Given this list of marker genes PYROXD1, SGCG, TNPO3, HACD1, EBF3, DNM1L, OBSL1, CHRNE, ANXA11, PAX3, GDF11, FKRP, ALG14, PTPN11, CRPPA, MYBPC1, ANO5, CHRNA1, PLIN4, FILIP1, TWNK, POLG2, MYMX, CHRNB1, DNMT3B, DYSF, SYNE1, TNNT1, SLC25A4, FRG1, CAPN3, MATR3, DPAGT1, DUX4, MYMK, KBTBD13, EYA1, BRAF, POMT2, AK9, GALC, DMD, TMEM43, MT-TE, CFL2, TRPS1, COLQ, DNA2, PNPLA2, PSAP, GNE, ACTA1, MYOT, VCP, ABHD5, SQSTM1, LRP4, SALL4, HNRNPDL, TTN, SELENON, TRIM32, GFPT1, COL13A1, GMPPB, POLG, FHL1, SYNE2, TK2, KLHL41, ATP6V0A2, ALX1, NEFL, ALX3, SGCB, MYH2, OPA1, RYR1, COL6A2, MYH7, COL6A1, PAX1, LAMB2, DNAJB6, ITGA7, SCN4A, FKTN, DUX4L1, GDAP1, LMNA, TBX3, SEPTIN9, ITPR1, SPEG, COL12A1, VWA1, MYL2, EMD (emerin), SMPX, MYPN, SMN1, RYR3, LGI4, GYG1, FLNB, PLXND1, COL6A3, SPTLC1, TRIO, TPM3, SMN2, CSGALNACT1, RAF1, FLNA, SPRED2, PRR12, PUS1, ASH1L, AGRN, REV3L, CRYAB, C19orf12, TPM2, SMCHD1, CUL7, FBN1, POGLUT1, BIN1, RBM8A, DSTYK, ALG2, MUSK, TRPV4, NEB, EMILIN1, CCDC8 (NCBI Gene Id 83987), TBX5, DOK7, BICD2, RAPSN, TGFB3, MAP3K7, SGCA, FLNC, CHRND, MAP3K20, RRM2B, KCNJ2, LRIF1, SGCD, BAG3, here is a description of the gene set: Abnormality of the shoulder girdle musculature species: Homo sapiens Human Gene Set: HP_ABNORMALITY_OF_THE_SHOULDER_GIRDLE_MUSCULATURE